The following is a description of a gene set: studied in species Mus musculus Genes down-regulated both in group C and D of tumors arising from overexpression of BCL2L1 and MYC in plasma cells. from publication Boylan KL, Gosse MA, Staggs SE, Janz S, Grindle S, Kansas GS, Van Ness BG (PMID 17483317) Mouse Gene Set: BOYLAN_MULTIPLE_MYELOMA_C_D_DN Multiple myeloma is an incurable plasma cell malignancy for which existing animal models are limited. We have previously shown that the targeted expression of the transgenes c-Myc and Bcl-X(L) in murine plasma cells produces malignancy that displays features of human myeloma, such as localization of tumor cells to the bone marrow and lytic bone lesions. We have isolated and characterized in vitro cultures and adoptive transfers of tumors from Bcl-xl/Myc transgenic mice. Tumors have a plasmablastic morphology and variable expression of CD138, CD45, CD38, and CD19. Spectral karyotyping analysis of metaphase chromosomes from primary tumor cell cultures shows that the Bcl-xl/Myc tumors contain a variety of chromosomal abnormalities, including trisomies, translocations, and deletions. The most frequently aberrant chromosomes are 12 and 16. Three sites for recurring translocations were also identified on chromosomes 4D, 12F, and 16C. Gene expression profiling was used to identify differences in gene expression between tumor cells and normal plasma cells (NPC) and to cluster the tumors into two groups (tumor groups C and D), with distinct gene expression profiles. Four hundred and ninety-five genes were significantly different between both tumor groups and NPCs, whereas genes were uniquely different from NPCs in tumor group C and genes were uniquely different from NPCs in tumor group D. Similar to human myeloma, the cyclin D genes are differentially dysregulated in the mouse tumor groups. These data suggest the Bcl-xl/Myc tumors are similar to a subset of plasmablastic human myelomas and provide insight into the specific genes and pathways underlying the human disease., and this is the list of marker genes: Vcam1, Krba1, Zbtb20, 5830444B04Rik, Cttn, Rnf128, P4ha2, Klra4, Itpripl2, Gpr174, Apol7c, Cfp, Icos, Mvb12b, Hba-a1, Slfn1, Rasgrp3, Ltb4r1, Trgv4, Mgam, Rras2, Tbc1d8, Mfsd4a, Hmgn3, Cxcr6, Mdfic, Igf1r, Gatm, Trbc1, Cers4, Zbp1 (NCBI Gene Id 80562), Ltb, Fos, Tent5c, Fosl2, Plscr1, Nkg7, Lilrb4b, Cpeb3, Cd226, Il13ra1, Atp6v0a1, Rsph1, Tpsb2, Gpr160, Irf6, Rgcc, Ctsw, Creld2, F2rl1, Vav3, Ifi204, Cd28, Spon1, Tnfrsf17, Tmem38b, Fpr1, Bscl2, Ccnd2, Basp1, Scart1, Tgfbi, Trgc1, Rhob, Tmem154, Smad1, Ctsg, Cfap61, Rgs18, Slfn4, Trgc4, Gimap4, Selenop, Ada, Pygl, 2310061I04Rik (NCBI Gene Id 69662), Coro2b, Sema4f, Fam219a, Pik3cb, Gpr183, Rab3d, Cep250, Kdf1, Enpp1, Slc16a5, Camp, Cacna1s, Zbtb16, Ly6a (lymphocyte antigen 6 family member A), Rtp4, Fads3, Ptpn22, Armcx3, Cd177 (CD177 antigen), Sgms2, Lpar4, Fscn1, Ms4a1, Elane, Entpd1, Gda, F2r, Sec24d, Wipi1, A430035B10Rik, Kit, Gm11992, Rora, Fyb1, Cd3g, Nbea, Edem1, C3, Dcpp1, Tgtp1, Ttc39b, Tmem176a, Mmp8, Gpm6a, Clec4e, Gimap8, Pglyrp1, S100a8, Olfm4, Slco3a1, Dnajb14, Ms4a4b, Raph1, Nfil3, Gbp8, Trim30d, Afp, Klrc1, Il2rb, S100a9, Cacnb3, Cd9, Plcb4, Ifi207 (NCBI Gene Id 98407), Steap4, AA467197, Maf, Ptpre, Olfm1, Ifitm6, Crisp3, Aqp3, Itgal, Ell2, Ctla2a, Hook1, Inpp4b, Dclre1b, Ifitm3, Eaf2, Rgs13, Taf9b, Lax1, Osbpl3, Kdelr3, Hp, Eomes, Id2, Ccl5, Tns3, Slpi, Prlr (prolactin receptor), Mcpt4, Cldn7, Sntb1, Xdh (xanthine dehydrogenase), Prg2, Oosp2, Cd7 (NCBI Gene Id 12516), Arfgap3, Pon3, Khk, Saraf, Fndc3b, Tspan2, Fgl2, Trdc, Casp4, Amy1, Ly6c1, Gm36723, Rmdn2, Hsd11b1, Ldhb, Mmp9, Cryba4, Megf9 (NCBI Gene Id 71014), Plaat3, Lrp12, Slc41a2, Lcn2, Prtn3, Trim34a, Rhpn2, Sirpb1a (NCBI Gene Id 320832), Frmpd2, Chst1, Ms4a2, Tfec, Tmem176b, Sqor, Plpp5, Ggh, Stfa1, Pawr, Il18rap, Slco4c1 (solute carrier organic anion transporter family, member 4C1), Gzma (granzyme A), Gabra4, Ngp, Arl4c, Myo1f, Arsg, Cd3d, St8sia6, H2-Q6, Wfdc17, Farp2, Lrg1, Rab32, Klrk1, Scamp1, Pirb, Tiam1, Gvin1, App (NCBI Gene Id 319425), Ear1, Slc25a24, Hid1, Runx2, H2-Q2, Zfp467, Klrd1, Epcam, Cp, Cd3e, Plek, Spag6, Dsp, Dsg2 (NCBI Gene Id 52489), Oosp1, Cdh2, Arhgap6, Rnf215, Armcx2, Mcemp1, Selenom, Gbp6, Lyz2, Hdc, C230085N15Rik (NCBI Gene Id 320556), Alcam, Mpo, Cacna1h, Serpina3g, Ltf, Speer1a, Ifi202b, Cd8b1, Gramd1c, Itk, Sema4a, Itga1, Iqgap2, Fam135a, Gpc1, Sh2d1a (SH2 domain containing 1A), Prdm1, Stat4, Anxa2, Isg20 (NCBI Gene Id 80487), Pafah2, F13a1, Chil3, Dhrs3, Upp1, Ccr2, B3galnt1, Elovl7, Abi3bp, Gramd1b, Reck, Plin3, Tbx21, Prkcq, Gca, Stfa2l1, Cpe, P2ry14, Igsf6, Traj20, Etl4, Il18r1, Oxr1, Itgb5, Mcpt8, Gnaz